Given this list of marker genes PRLR, GH1, PTPN11, GH2, CUL1, JAK2, CSH1 (chorionic somatomammotropin hormone 1), RBX1, GHR, STAT5A, STAT5B, SH2B1, BTRC, PRL, SKP1, here is a description of the gene set: species: Homo sapiens Prolactin receptor signaling Human Gene Set: REACTOME_PROLACTIN_RECEPTOR_SIGNALING